The following is a description of a gene set: species: Mus musculus Any process that activates or increases the frequency, rate or extent of execution phase of apoptosis. Mouse Gene Set: GOBP_POSITIVE_REGULATION_OF_EXECUTION_PHASE_OF_APOPTOSIS, and this is the list of marker genes: Fap, Trp53, Ndufa13, Ptgis, Bok, Casp8, Rbm10, Htra2, Hspd1, Tradd, Dlc1, Bcl10, Fadd, Zc3h12a, Ripk1, Tnfrsf1a, Sirt2, Trp53bp2, Cxcr3, Htr2a